Given this list of marker genes MIR6076, ARRDC3-AS1, HYCC2, RBBP4, CCNG2, BRD2, LINC02320, FNBP4, NDUFA2, ATP5PB, AQR, TMEM267, GABPB1-AS1, KXD1, GDF15, CEP120, CNTFR, PTCD3, VCPIP1, ZFAND5, IPO13, TRIB3, TARBP2, MARF1, COQ7-DT, ATPSCKMT, RBM48, SEPHS2, STX10 (syntaxin 10), CENPP, TRMT10A, DDX55 (DEAD-box helicase 55), PLA2G2A (phospholipase A2 group IIA), TNFRSF14, SFSWAP, SLC28A2-AS1, NOP16, NDUFB3, SNRPA1, MST1P2, BCLAF1 (BCL2 associated transcription factor 1), WARS1, NDUFAF5, ZNF169, NFKBIZ, EMG1, SNORD95, DRAIC, POLE3, USP53, HEXA-AS1, EEF1G, PEX1, SIRT4, VPS28, PPWD1, SREK1IP1, LINC03073, PLA2G6, LINC02889, ANKRA2, CLTC, TSPAN8, LINC02441 (NCBI Gene Id 105370070), NUP107-DT, FZR1, PRCC, ELP3, TPD52L2, SMARCE1, HDGF, NFKBIL1, ZNF557 (NCBI Gene Id 79230), OXA1L (OXA1L mitochondrial inner membrane protein), ENC1, HEXA, RACK1, TXN2, MARS1, WDR77, CAPZA2, SUMF2 (NCBI Gene Id 25870), SLC3A2, RHBDD3, ZSCAN21, TEP1, ARL1, MRPL48, SMIM15, HIGD2A, TNFSF9, MCTP2, RAPGEF6, SLC24A1, ADAMTSL4-AS1, GRK6, CT62, MARK4, TMCO4, DEDD, COASY, MACC1, UBLCP1, XRCC5, ATP10B, SELENOP, VPS33B-DT, DNAAF10, NCAPD2, SRSF5, LINC03015, WDR25, SPINK5, HBP1 (HMG-box transcription factor 1), SNRPA, DDX21, POLR2M, MYOF, LINC01730 (long intergenic non-protein coding RNA 1730), PPIP5K2 (NCBI Gene Id 23262), H2AC8, DUSP6, KPTN (kaptin, actin binding protein), SKIDA1, SYF2, ATP6V1G2, H3C11, LURAP1L-AS1, GRPEL2, SNX8, PPP1R37, CROCCP2, ZMAT2, SPHK2, LRIF1, HARS1, MAN2C1, COG5, GABPA, SH2B1, IER3-AS1, ZDHHC6, MRPL1, BEST1, TBC1D5, H2BC8, MRPL13, S100A10, AKT1S1, VEGFA, APLF, CTSO, TMEM62, KIF2C, RNU5B-1, NUCKS1, UGT1A6, PCBP1-AS1, SNORD49A, LAD1, CENPK, GABPB1, KCNK1, TRIM31, SLC7A11, COX7A2L, ARRDC3, RAD51AP1, MKKS, CAMLG, SLX4IP (NCBI Gene Id 140682), FXYD3, ZC3HC1, WDR74, PPIA, BSCL2, EIF2S1, NKAPD1, MRPL43 (mitochondrial ribosomal protein L43), HOXA-AS3, PHB2, GANC, WRAP53, LINC02918, THRB-AS1, NAPA-AS1, IDH3B-DT, FDXACB1, NDUFA4 (NCBI Gene Id 4697), BRAT1, SNORA73A, TANK-AS1, MCCC2, ZMYM6, APBB3, EIF3B, EGR2, CDKN1B, FCSK, SOX30, PSMC3, GIN1, SPAG1, LINC01132, PRKCI, CYP1B1-AS1, CTDSPL2, RPL22L1, EGR1, TBC1D17, FNBP1P1, TMEM87A, DDIT4, LUC7L2, RBM4, GIRGL, POLR1A, ATP6V1D, HSPA4 (heat shock protein family A (Hsp70) member 4), PDE4D, TPI1P2, PSAT1, SEMA3C, ZNF207, LSM8, PHYKPL, MRPS33, BAG6, CHD2, NFX1, ING3, MRPL46, ATG13, CLDN4, S100A11, FERRY3, JMY, CFAP68, ESF1, TXNDC12, THBS4, LSM5, CLIC1 (NCBI Gene Id 257617), NDUFA5, THRB, TSG101, TAF15, GAPDHP25, DOHH, HSD17B2, HOXA9, NUP155, MRPS12, RBBP5, MALSU1, ATP6V1G2-DDX39B, CMSS1, C11orf71, LINC-PINT, CWC25, IMMP1LP1, TASOR2, GLOD4, TWNK, UTP15, RPS14, MRPS11, CHP1, SNX1, HARBI1, B9D2, ACTMAP, LINC01411, EXD1, PRLR, SEC11A, RPL7L1P8, SLTM, PPP2R5B, PTCD2, HNMT, SRI, KCTD16, TRIM52-AS1, ZRANB3, AGR2, ERBB3, MYL12A, EDC3, CCT5, TNPO3, AKAP9, PBX1, PRDM1, GCHFR, PMVK, LRP6, MTTP, RPL41, CAND1, PYGB (NCBI Gene Id 5834), IDH3B, PPP2R5C, DPH6-DT, ZNF106, CHAC1, AGPS, VPS50, TSGA10, AVL9, PRR15, DNMBP, YIPF5, SRSF1, UIMC1, C5orf52, FAM53C, BTF3L4, SERPINH1, DCLRE1A, MIR5687, IK, SNORD35B, TFAP2A (transcription factor AP-2 alpha), EWSR1, MDC1, SNAP23, COPB1, HOXA11-AS, CCDC192, MRPL11, SMIM12, LINC01588, NOL8, IPO11, PIH1D2, VPS33B (NCBI Gene Id 55513), CHMP4C, PAAF1, ZBTB8OS, GTF2IRD1, TIMM13, SUB1, SH2D4A, FAM168A, BRCA1 (NCBI Gene Id 672), CCDC97, NHLRC2, METTL8, RBCK1, ACAD9, MRM3, USP3, WDR89, R3HDM1, CIRBP, SETD1A, COQ7, PIPOX, METTL15, HARS2, KPNB1, KCMF1, ZNF770, SCAP, CASD1, SLC30A4-AS1, GAPVD1, NOP58, FBXO48, TMEM9, PPP1R1B, TRMT61B, IFNAR1, TBC1D1, SARS2, RNF186-AS1, MTIF2, TRIM52, SLC35A4, GNS, PHF12, MRPL51 (mitochondrial ribosomal protein L51), KHDC4, RPL32P3, CFDP1, MTIF3, INTS14, MIR4727, PNO1, C17orf75 (NCBI Gene Id 64149), FMC1, SNHG3, ETFBKMT, FBXW11, ZNF608, FOXP1, NUP107, PPFIBP2, VTI1A, DMTF1-AS1, MTBP, LINC02924, SEC61A1, SUCLG1, EXO1, ATXN2L, ECH1, RNF186, CTDSPL2-DT, RPL18, DCAF17, GPR160, NBPF1, LINC03014 (long intergenic non-protein coding RNA 3014), C9orf43, here is a description of the gene set: from publication Yevshin I, Sharipov R, Kolmykov S, Kondrakhin Y, Kolpakov F (PMID 30445619) studied in species Homo sapiens Human Gene Set: DMRT1_TARGET_GENES Genes containing one or more binding sites for (DMRT1) in their promoter regions (TSS -1000,+100 bp) as identified by GTRD version 20.06 ChIP-seq harmonization.